Given this list of marker genes Nfkbia, Gbp4, Sumo1, Chp1, Mdfic, Hnf4a, Pkia, Sirt6, Ywhab, Nf1, Rab23, Fermt1, Cabp1, Apod, Angpt1, Ei24, Akap1, Pkig, Ufm1, Cd36, here is a description of the gene set: species: Mus musculus Mouse Gene Set: GOBP_NEGATIVE_REGULATION_OF_PROTEIN_IMPORT_INTO_NUCLEUS Any process that stops, prevents, or reduces the frequency, rate or extent of the movement of proteins from the cytoplasm into the nucleus.